Given this list of marker genes VPS37D, EIF4E2, C10orf88, RNU7-27P, PSMD14, MRPL44, IGHMBP2, NDUFS3, GFM2, NOC4L, DDX51, DCP1A, NUF2, SUGCT, GALNS, TBC1D5, SLC12A2-DT (NCBI Gene Id 649121), TESC-AS1, STX18-AS1, STEAP1, ADA, BORCS8-MEF2B, TUT1, SRP54, RNF213, GGH, ARID1A (AT-rich interaction domain 1A), TESC, MTMR9, LINC01409, VPS9D1, TACO1, AGK-DT, PIK3CA, MYH10, PIK3AP1, DESI2, VPS13B-DT, AFG2A, MINPP1, RGS5, METTL9, RUNX1T1, PDZD8 (PDZ domain containing 8), LIG4, ANAPC5, TGFB2-AS1, SEPTIN7P14, PSMD14-DT, PPP3CC (NCBI Gene Id 5533), ENSG00000253986, JPX, ATG4B, NSA2, DDX55, GLUD1P3, SYDE2 (NCBI Gene Id 84144), MRPL21, REV3L, PEX3, RESF1, BORCS8, HIPK3, OSBPL6, PALM3, EIF3F, AHDC1, TVP23B, CLK1, MEGF9, PCLAF, SGPP1, IZUMO4, GPBP1, POC1B-GALNT4, LILRB3, YIPF2, ANO8, PIH1D2, STX16-NPEPL1, CYREN, TIGD1, ZNF792, CWC27, MYC, MRPL39, PSMG3-AS1, CHKA-DT, GARS1, STIM2-AS1, PUS10, SENP1, INTS12, MITD1, PPEF1, SZRD1, DYRK1A, USP30, AP3S2 (NCBI Gene Id 8885), MOB3A, NDUFB3, NFATC3, VILL, FBXW8, TJP3, SMG7-AS1, USP46, WDR83, NR3C1, EXOSC3, ZNF687, SLC37A3, TRAF3IP2-AS1, SUCLG2-DT, SLC29A3, ZNF580, MRPL13, UBTF, MRPS31, SLC12A2, ACP2, VPS13B, SLC30A1, PFKM, UBE2O, ECPAS, HIRA, ZSCAN2-AS1, SLC35D1 (solute carrier family 35 member D1), MPLKIP, NFIX, CPEB2, CCNC, MBTPS2, WDR83OS (NCBI Gene Id 51398), CAMSAP1, FCHO1, EFCAB7, ZNF596, PIK3CA-DT, SLC4A1AP, UBE3B, NMUR1, FAM13A, ZNF408, UNC119, NEMP2, RANBP9, LMTK2, SH3KBP1, CDK13, TRIP4, NDE1, NR1H3, OTUD3, GOLGA3, AGK (acylglycerol kinase), POC1B, C12orf76, ATXN1-AS1, CDK13-DT, GFOD1, LRP6, GATA6-AS1, PCID2, LINC01547, ZNF276 (zinc finger protein 276), TMEM41A, ZNF581, PIGZ, ZNF391, CMPK2, DENND4C, IMPA2, SLC8B1, TEFM, SNRPB, SUPT7L, TIMM29, STX16, ZDHHC6, COMMD2, LINC02798, ZNF248, DRG2, RBBP5, CSNK1D, ITGB3BP, ISY1-RAB43 (ISY1-RAB43 readthrough), LINC02202, SLC39A3, CDK11B, BMS1P4, TOR1AIP1, ZNF561-AS1, KIF2A, MTBP, GTF3C5, DOCK7, LINC01748, ARHGEF7, ZMPSTE24-DT, SF3A3, TP53RK-DT, GSTCD, IKZF3, WSCD2, RNVU1-15, NEMP2-DT, CUL4A, SUCLG2, SAMD1, INTS5, VTI1A (NCBI Gene Id 143188), TWSG1-DT, MRPL40 (mitochondrial ribosomal protein L40), ETS2-AS1, STIM2 (NCBI Gene Id 57620), REXO4, MFAP3L, NKAPD1, RPS7, PSMA1, FRA10AC1, MRPS5, VAT1 (vesicle amine transport 1), MBOAT2, SNAP47, TPI1P2, STX18, SRP54-AS1, LUZP1, TNPO3, SEMA4B, TATDN3, ABHD13, VPS51, NFATC4, GMFB, USP46-DT, TMEM50B, ZBTB45, KLHDC1, DOCK7-DT, MARCKSL1P2, NSL1, MRPL58, PTP4A3 (NCBI Gene Id 11156), TGFB2, MKRN3, MRPL45P2, KIF16B, TBC1D19, NSMAF, TLE3, CPEB2-DT, GTF2IP12, THUMPD2, NDUFAF1, PSTK, FOXL1, BMS1P4-AGAP5, TRIP10, SGSM1, EGLN1P1, PSMG3, CHKA, ZFP69, TMEM65, WDR37, INCA1, HEBP2, RBM28, TP53BP2, ADAT2, CCDC144BP, CTNNB1, DDX11L10, SCAND2P, PSMF1, RNA5SP324, RCL1, KBTBD4, ZBTB34 (zinc finger and BTB domain containing 34), SELENOH, TUBGCP3, GTPBP3, JMJD4, ZNF638, ISY1, TFAP4, MPPE1 (NCBI Gene Id 65258), MTERF4, SLX9, TLNRD1, GLI1, GTF2E2, WDR36, ZMPSTE24, PDLIM1, BRF2, MAIP1, MRTFA, MIDN, KCTD10, CELSR2, SMG7, RSAD2, ENSG00000232995, CCDC97, H3P47, KIF1C (NCBI Gene Id 9713), DNAJB11, KAT2B, NDUFS7, ZNF561, C1orf159, GARS1-DT, SMG1P3, PDE4C, PPP1CC (NCBI Gene Id 5501), MRPL48, RASA1, CCAR2, HDAC8, MRPL30, PPARGC1B, DUS1L (NCBI Gene Id 64118), TYW5, IPO4, RPL23AP53, METTL15, HYCC2, IL1R1, ST8SIA6, PEX13, TMEM222, MRPL3, GLCCI1, CCDC6, IFT56, PLCD3, RMND5B, SREK1IP1, ADAP2, DSTYK, MIR193B, RFXANK, FAM234B, CD274, NUDT6, ARHGAP1, here is a description of the gene set: Human Gene Set: RLF_TARGET_GENES studied in species Homo sapiens from publication Yevshin I, Sharipov R, Kolmykov S, Kondrakhin Y, Kolpakov F (PMID 30445619) Genes containing one or more binding sites for (RLF) in their promoter regions (TSS -1000,+100 bp) as identified by GTRD version 20.06 ChIP-seq harmonization.